Given this list of marker genes NT5C2, GDA, NUDT1, NUDT5, DNPH1, NT5C, NUDT16, ADPRM, NUDT9, NUDT15, XDH, NT5E, ITPA (NCBI Gene Id 89313), NT5C1A, NT5C1B, NUDT18, PNP, here is a description of the gene set: studied in species Homo sapiens Purine catabolism Human Gene Set: REACTOME_PURINE_CATABOLISM